Given this list of marker genes DPAGT1, ALG2, ALG1, ALG11, ALG14 (ALG14 UDP-N-acetylglucosaminyltransferase subunit), ALG13 (ALG13 UDP-N-acetylglucosaminyltransferase subunit), here is a description of the gene set: Pathway Definition from KEGG: P-Dol -- ALG7 >> (ALG13+ALG14) >> ALG1 >> ALG2 >> ALG11 -> G00006 Human Gene Set: KEGG_MEDICUS_REFERENCE_N_GLYCAN_PRECURSOR_BIOSYNTHESIS_ALG7_TO_ALG11 N-Glycan precursor biosynthesis, ALG7 to ALG11. Pathway ID: N00653. Pathway type: Reference. Pathway class: nt06015 N-Glycan biosynthesis. studied in species Homo sapiens